Given this list of marker genes MMP1, PARG, WASF1 (WASP family member 1), TP53, TP53I3, VCAM1, MEIS1, TOMM70, CDC14A, PRKAR1B, DNMT3A (DNA methyltransferase 3 alpha), EFNB3, STAB1, PCK2, STAM, PLAU, here is a description of the gene set: from publication Geiss G, Jin G, Guo J, Bumgarner R, Katze MG, Sen GC (PMID 11487589) Genes down-pregulated by dsRNA in GRE cells (glioma; no interferon system). Double-stranded (ds) RNA, a common component of virus-infected cells, is a potent inducer of the type I interferon and other cellular genes. For identifying the full repertoire of human dsRNA-regulated genes, a cDNA microarray hybridization screening was conducted using mRNA from dsRNA-treated GRE cells. Because these cells lack all type I interferon genes, the possibility of gene induction by autocrine actions of interferon was eliminated. Our screen identified 175 dsRNA-stimulated genes (DSG) and 95 dsRNA-repressed genes. A subset of the DSGs was also induced by different inflammatory cytokines and viruses demonstrating interconnections among disparate signaling pathways. Functionally, the DSGs encode proteins involved in signaling, apoptosis, RNA synthesis, protein synthesis and processing, cell metabolism, transport, and structure. Induction of such a diverse family of genes by dsRNA has major implications in host-virus interactions and in the use of RNA(i) technology for functional ablation of specific genes. Human Gene Set: GEISS_RESPONSE_TO_DSRNA_DN species: Homo sapiens